Given this list of marker genes Bcl9, Ptgfrn, Tmem182, Cd81, Mymx, Myod1, Synb, Klf5, Cd9, Mymk, here is a description of the gene set: The process in which a relatively unspecialized cell acquires specialized features of a myotube cell. Myotube differentiation starts with myoblast fusion and the appearance of specific cell markers (this is the cell development step). Then individual myotubes can fuse to form bigger myotubes and start to contract. This process occurs as part of the process of skeletal muscle regeneration. Myotubes are multinucleated cells that are formed when proliferating myoblasts exit the cell cycle, differentiate and fuse. Mouse Gene Set: GOBP_MYOTUBE_DIFFERENTIATION_INVOLVED_IN_SKELETAL_MUSCLE_REGENERATION studied in species Mus musculus